Given this list of marker genes RPA1, CUTC, MAN2B2, KYNU, PPP1R7, PAXBP1, CPQ, NPIPA1, OXLD1, PTGER2, CRNKL1, PIGH, RB1CC1, ERCC3, MLST8, ACOX1, PAIP2, CCL26, NUP155, FADS2, NDUFC2, TKT, HAUS1, REEP5, MKRN1, EML4, AFG2B, DDX17, RAP1GDS1, COMMD1 (copper metabolism domain containing 1), CCSAP, ACAD8, TMEM14C, BLTP2, METTL23, MEN1, NLRC4, SUOX, CHCHD7, RYK, CDC23, GAB3, HDGF, SPINT2, DNAAF5, FCGRT, CBX1, DDX18, IFNAR2 (NCBI Gene Id 3455), EEPD1, KDM2B, PRMT1, KLHL9, COMMD3, AUP1, MAF, ADI1, ATRAID, APOO, ZFP36L1, RNFT1, SIGLEC17P, PRKDC, SDF4, SLC25A36, TMEM53, ANKMY2, NUP85, PELI2, IMPDH1, ZZEF1, NUP93, TAPT1, ZCCHC9, CERK, CAMK1D, MCM9, NUDCD2, UMPS, EPHX1, STMP1, DHX29, PARP1 (NCBI Gene Id 142), GMPR2, CCL17, CDC40, MRPL36, SOCS6, PLOD1, CRIM1, SYNJ1, ZNF559, FLVCR2, MAOA, CCT7, RAB4A, ACSL3, GPX1, PKD2, PIGC, BMI1, SHPRH, FIG4, SUCLA2, HSD17B4, MS4A4A, MKKS, NUTF2, ARRDC4, EEF2K, PWWP2A, IDH1, GAS2L3, FBXL17, RIOK2, AKR1B1, ZNF664, ZDHHC3, MRPS7, BNIP3, RNF20, SAYSD1 (SAYSVFN motif domain containing 1), ZC3H14, TTC9C, EMB, EIF3J-DT, MRRF, CHD2, GSTP1, ETFB, PPCS, PLIN2, CNOT6L, NUDT16L2P, PHF10, PIK3CD, CMSS1, CH25H, FBXO42, H2AZ2 (H2A.Z variant histone 2), SCD, UBE2I, WRNIP1, UTP18, ACACA, DTX4, BTBD6, FH, SNX1, FCER2, CHST7, TSN (NCBI Gene Id 7247), DENND4C, FBXO9, PRKCI, CSE1L, ACAD9, RSAD1, CHD1, DCAF7, OLFML2B, PALLD, FABP4, CDK5, TYW3, ETV6, MAPK1, BZW2, DHCR24, VPS26B, ZNF518B, GALNT1, FN3KRP, MRPL13 (mitochondrial ribosomal protein L13), ZNF585A, ACVR2A (activin A receptor type 2A), MIS18BP1, ZNF131, NFXL1, MRTFB (NCBI Gene Id 57496), MCCC1, OTUD6B, KCNK6, GRK3, KCNE1, C2orf69, ANP32B, HMGB1, ECH1, SLC6A6, NDUFA8, TRMT61B, ATP13A5, ZCCHC14, MAPKAPK5, WBP11, PCM1 (pericentriolar material 1), ZNF700, CHCHD10, PRPS1, here is a description of the gene set: Human Gene Set: GSE1740_MCSF_VS_MCSF_AND_IFNG_DAY2_DERIVED_MACROPHAGE_WITH_IFNA_STIM_UP from publication Tassiulas I, Hu X, Ho H, Kashyap Y, Paik P, Hu Y, Lowell CA, Ivashkiv LB (PMID 15467722) Genes up-regulated in monocyte-derived macrophages: no priming, stimulated by interferon alpha versus primed by IFNG and then stimulated by interferon alpha. Type I IFN-inducible gene expression in human blood monocytes primed with Type II IFN. species: Homo sapiens